The following is a description of a gene set: Human Gene Set: HP_ABNORMAL_CIRCULATING_FATTY_ACID_CONCENTRATION Abnormal circulating fatty-acid concentration studied in species Homo sapiens A deviation from the normal concentration of a fatty acid in the blood circulation., and this is the list of marker genes: TRMU, DOLK, LMBRD1, SLC12A1, SLC34A1, ACADS, PLA2G4A, REPS1, ABCD1, GCDH, NADK2, CTNS, LTC4S, PEX2, GATM, MMP1, PEX1, ABCC8, HADHA, PEX7, AMACR, NDUFA2, LYRM7, MCEE, BCAP31, TANGO2, SCO1, MMACHC, EHHADH, PHYH, SLC25A20, ATAD1, AKT2, PEX16, MCCC2, NDUFAF6, PEX10, PEX14, ABCD4, PEX11B, SLC52A1, AP1S1, HSD17B4, PEX5, PEX12, PEX19, ACAD8, COL7A1, PEX13, UCP2, DNM1L, ACADVL, HADH, KCNJ11, CPT2, SCP2, COX16, IVD, HMGCS2, ACAD9, DLD, PGM2L1, ACADM, KCNJ1, PEX3, SLC22A5, ETHE1, LMNA, PEX26, HNF4A, MT-TE, MMAB, GLYCTK, PEX6, HMGCL, HNF1A, OBSCN